Given this list of marker genes PDIA3, HLA-A, TAPBPL, TAPBP, B2M, CALR, here is a description of the gene set: species: Homo sapiens The binding of a peptide to the antigen binding groove of an MHC class I protein complex. Class I here refers to classical class I molecules. Human Gene Set: GOBP_PEPTIDE_ANTIGEN_ASSEMBLY_WITH_MHC_CLASS_I_PROTEIN_COMPLEX